The following is a description of a gene set: studied in species Mus musculus Mouse Gene Set: GOBP_POSITIVE_REGULATION_OF_INTERFERON_ALPHA_PRODUCTION Any process that activates or increases the frequency, rate, or extent of interferon-alpha production., and this is the list of marker genes: D1Pas1, Tlr7, Tlr4, Irf3, Zc3hav1, Setd2, Tlr3, Trim65, Chuk, Hmgb1, Ifih1, Tbk1, Irf7, Dhx36, Tlr8, Ddx3x, Nmb, Ptpn22, Nmbr, Hspd1, Flt3, Traf3ip3, Rigi, Mavs, Tlr9, Stat1, Mmp12, Dhx9